Given this list of marker genes Pcna, Mcm8, Rps27a, Psmd13, Rpa1, Fzr1, Cdc26, Kpna1, Psma5, Anapc10, Psmd7, Mcm4, Anapc15, Psmb6, Cul1, Cdc6, Orc3, Mcm2, Psma3, Kpna6, Psmc1, Psmd1, Anapc7, Ube2c, Cdc23, Psmc2, Psma6, Pold4, Psma4, Mcm7, Pole (NCBI Gene Id 18973), Gins3, Pold1, Pola1, Ccne1 (cyclin E1), Psma7, Anapc2, Psmb4, Orc5, Psmb7, Ube2s, Gmnn, Cdc45, Lig1, Orc4, Ccne2, Pold2, Dna2, Rfc1, Pola2, Rfc3, Ube2e1, Ubb, Psmc6, Psmd12, Dbf4, Psmd6, Psmb5, Psma1, Prim1, Ube2d1 (NCBI Gene Id 216080), Ccna1, Gins1, Psmc4, Orc1, Cdc7, Psma2, Polg2, Kpnb1, Psmc3, Pole2, Psmc5, here is a description of the gene set: This event has been computationally inferred from an event that has been demonstrated in another species.<p>The inference is based on the homology mapping from PANTHER. Briefly, reactions for which all involved PhysicalEntities (in input, output and catalyst) have a mapped orthologue/paralogue (for complexes at least 75% of components must have a mapping) are inferred to the other species. studied in species Mus musculus electronically inferred by orthology from the curated human pathway Reactome Pathway: DNA Replication